Given this list of marker genes TMEM67, ALG5, ZMIZ1, MAFB, DCDC2, PAX7, MUC1, here is a description of the gene set: Atrophy of the kidney. Renal atrophy studied in species Homo sapiens Human Gene Set: HP_RENAL_ATROPHY